Given this list of marker genes Grk2, Npr2, Ptx3, Adrm1, Ptprn, Esr1, Pla2g4a, Oas1d, Gpr149, Pdgfra, Mmp2, Gas2, Stat5b, Scaper, Ereg, Lhcgr, Chrna7, Myh9, Runx1, Stat5a, Arrb2, 2610005L07Rik, Plekha1, Fzd4, Casp3, Casp2, Agt, Sohlh2, Mfn2, Adamts1, Amh, Kiss1, Nppc, Zp3, Map2k6, Afp, Nos3, Fshb, Retn, Tnfaip6, Bmpr1b, Schip1, Nr5a1, Slit3, Foxo3, Fshr, Nrip1, Zfp830, Npy5r, Ptger4, Lep, Edn2, Gdf9, A2m, Inhba, Pde4d, Nos2, Sirt1, Sgpl1, Pgr (NCBI Gene Id 270116), Mstn (myostatin), Src, Arrb1, Notch1, Mmp19 (matrix metallopeptidase 19), Nr5a2, here is a description of the gene set: Mouse Gene Set: GOBP_OVULATION_CYCLE_PROCESS A process involved in the sexual cycle seen in females, often with physiologic changes in the endometrium that recur at regular intervals during the reproductive years. studied in species Mus musculus